The following is a description of a gene set: Neuronal loss in central nervous system species: Homo sapiens Human Gene Set: HP_NEURONAL_LOSS_IN_CENTRAL_NERVOUS_SYSTEM, and this is the list of marker genes: TBCD, SLC9A6, NPC1, VAC14 (VAC14 component of PIKFYVE complex), PSEN1, C9orf72, PIGA, MT-TT, POLG, CTSF, BSCL2, CTSD, MAPT, ATXN3, GBA1, CSF1R, CHMP2B, SERPINI1, BRAT1, GRN (NCBI Gene Id 2896), NARS2, DNMT1, PDYN, SNCAIP, NR4A2, FUS, SCO2, FIG4, VAPB, PLA2G6 (NCBI Gene Id 8398), VPS13C, ATXN8OS, ATXN2, TBP, ZNHIT3, ADH1C, PSAP, KCNT1, HTT, PRNP